The following is a description of a gene set: species: Mus musculus HSF1-dependent transactivation Mouse Gene Set: REACTOME_HSF1_DEPENDENT_TRANSACTIVATION, and this is the list of marker genes: Hspa1b, Camk2a, Cryab, Hsf1, Hspb8, Ptges3, Dnajb1, Hspa8, Hsbp1, Mtor, Akt1s1, Camk2b, Camk2d, Mlst8, Hsp90aa1, Hsp90ab1, Rptor, Camk2g (calcium/calmodulin-dependent protein kinase II gamma), Fkbp4, Hspa1a, Hspa2, Hspa1l, Ep300